Given this list of marker genes YOD1, UBAC2, ERLEC1, DERL2, BCAP31, UBE2J1, EDEM2, EDEM1, SVIP, OS9, UBE2G2, DERL3, BRSK2, here is a description of the gene set: Human Gene Set: GOBP_REGULATION_OF_RETROGRADE_PROTEIN_TRANSPORT_ER_TO_CYTOSOL Any process that modulates the frequency, rate or extent of retrograde protein transport, ER to cytosol. species: Homo sapiens